The following is a description of a gene set: studied in species Homo sapiens EGF-EGFR-PLCG-CAMK signaling pathway. Pathway ID: N00026. Pathway type: Reference. Pathway class: nt06273 Glioma. Pathway Definition from KEGG: EGF -> EGFR -> PLCG -> IP3 -> Ca2+ -> CALM == CAMK Human Gene Set: KEGG_MEDICUS_REFERENCE_EGF_EGFR_PLCG_CAMK_SIGNALING_PATHWAY, and this is the list of marker genes: EGFR, CALM2, CAMK1G, CAMK2A, EGF (NCBI Gene Id 1950), CAMK1 (calcium/calmodulin dependent protein kinase I), CALM3, CALM1, PLCG2, CAMK1D, CAMK4, PLCG1, CAMK2B, CAMK2G, CAMK2D